The following is a description of a gene set: Hypointensity of cerebral white matter on MRI Human Gene Set: HP_HYPOINTENSITY_OF_CEREBRAL_WHITE_MATTER_ON_MRI A darker than expected signal on magnetic resonance imaging emanating from the cerebral white matter. species: Homo sapiens, and this is the list of marker genes: ADORA2A, ADSL, UBE2A, GFM2, GALC, LAMA2, ZEB2, PSAP, POLG, TYMP, SAMHD1, KARS1, FDXR, TREX1